The following is a description of a gene set: Any process that modulates the frequency, rate or extent of a digestive system process, a physical, chemical, or biochemical process carried out by living organisms to break down ingested nutrients into components that may be easily absorbed and directed into metabolism. Mouse Gene Set: GOBP_REGULATION_OF_DIGESTIVE_SYSTEM_PROCESS species: Mus musculus, and this is the list of marker genes: Prap1, Apoa2, Cyp8b1, Tac4, Nmu, Hamp, Lep, Cldn15, Neurog1 (neurogenin 1), Ghrl, Lpcat3, Hip1r, Gpr39, Npr3, Wnk1, Slc22a21, Tff2, Aqp1, Wnk4, Crh, Kcnq1 (potassium voltage-gated channel, subfamily Q, member 1), Epb41, Tifab, Ptger3, Pawr, Dgat1, Npsr1, Hamp2, Crhr2, Ppp3ca, Slc22a5, Wnk3, Abcg8, Oxt, Abcb1a, Abcg2, Tymp, Nr1h3 (NCBI Gene Id 99182), Isx, Sct, Stk39, Oprk1, Enpp7, Abcg5, Negr1, Nr1h2, Apoa4, Cldn2, Apoa1, Ghsr, Neurod1, Acat2, Fgf10